The following is a description of a gene set: studied in species Homo sapiens Any process that activates or increases the frequency, rate or extent of T-helper 17 cell lineage commitment. Human Gene Set: GOBP_POSITIVE_REGULATION_OF_T_HELPER_17_CELL_LINEAGE_COMMITMENT, and this is the list of marker genes: OPA1, BRD4, IL12B, IL23A (NCBI Gene Id 51561, interleukin 23 subunit alpha), EP300, IL12RB1, BRD2, IL23R